Given this list of marker genes OTC, LDHC, HADH, CBS, SLC25A5, SLC25A15, ENO3, SLC7A2, MDH2, ALDOA, CPS1, GPT, SLC1A5, MOCS1, SLC2A3, PKLR, SLC25A1, ASS1, PC, SLC2A4, ACAT1, LDHA, SLC2A1, GLUD1, GAMT, CTH, G6PC1, TPI1, PSAT1, GCK, GOT2, MDH1, PHGDH, PGAM2, PFKM, GLS2, ARG1, DLD, PGK2, SFXN1 (sideroflexin 1), PSPH, ENO1, GOT1, MPC1, XDH, BTD, SPCS1, SQOR, SHMT1, SHMT2, ENO2, ALDH7A1, MOCS2, SUOX, HK2, ASL, PGK1, PDHA1, ALDOC, PFKP, GPHN (NCBI Gene Id 57566), PCK1, GLDC, LDHAL6B, PFKL, CDO1, GAPDH, AADAT, MOCS3, PGAM1, GCDH, PKM, GPI, ALDOB, MPC2, ETHE1, SLC2A5, HK1, ECHS1, LDHB, SLC2A2, GATM (NCBI Gene Id 65211), FBP2, AMT, DLAT, HK3, ACO1, HLCS, FBP1, DHTKD1, AASS, here is a description of the gene set: Metabolic epileptic disorders species: Homo sapiens Human Gene Set: WP_METABOLIC_EPILEPTIC_DISORDERS